The following is a description of a gene set: Enables the transmembrane transfer of a monoatomic cation by a channel that opens when ATP is bound by the channel complex or one of its constituent parts on the extracellular side of the plasma membrane. species: Mus musculus Mouse Gene Set: GOMF_EXTRACELLULARLY_ATP_GATED_MONOATOMIC_CATION_CHANNEL_ACTIVITY, and this is the list of marker genes: P2rx4 (NCBI Gene Id 52272), P2rx3, P2rx1, P2rx7, P2rx2, P2rx6, P2rx5